Given this list of marker genes ATG101, ATG14, MLST8 (NCBI Gene Id 64223), RB1CC1, PIK3R4, TTI1, BECN1, RPTOR (regulatory associated protein of MTOR complex 1), NRBF2 (NCBI Gene Id 91155), ATG13, AKT1S1, PIK3C3, DEPTOR (NCBI Gene Id 64798), TELO2, ULK1, MTOR, here is a description of the gene set: Autophagy-vesicle nucleation/elongation/maturation, mTORC1-PI3KC3-C1. Pathway ID: N00155. Pathway type: Reference. Pathway class: nt06532 Autophagy. species: Homo sapiens Pathway Definition from KEGG: mTORC1 -> ULK1_complex -> PI3KC3-C1 Human Gene Set: KEGG_MEDICUS_REFERENCE_AUTOPHAGY_VESICLE_NUCLEATION_ELONGATION_MATURATION_MTORC1_PI3KC3_C1